The following is a description of a gene set: species: Mus musculus Any process that decreases the rate, frequency or extent of a vitamin D biosynthetic process. Vitamin D biosynthesis is the chemical reactions and pathways resulting in the formation of vitamin D, any of a group of related, fat-soluble compounds that are derived from delta-5,7 steroids and play a central role in calcium metabolism. Specific forms of vitamin D include calciferol (ergocalciferol; vitamin D2) and cholecalciferol (calciol; vitamin D3). Mouse Gene Set: GOBP_NEGATIVE_REGULATION_OF_VITAMIN_D_BIOSYNTHETIC_PROCESS, and this is the list of marker genes: Snai2, Nfkb1, Snai1, Gfi1, Cyp27b1